The following is a description of a gene set: Human Gene Set: GOBP_NEGATIVE_REGULATION_OF_PROTEIN_NEDDYLATION Any process that stops, prevents or reduces the frequency, rate or extent of protein neddylation. species: Homo sapiens, and this is the list of marker genes: RPL5, COPS9, DCUN1D3, RPL11, CDKN2A